Given this list of marker genes Tap1, Atp6v1d, Atp1a1, Abca12, Atp6v1a, Abcd4, Abcb11, Abca15, Abcb1a, Atp7a, Ipo8, Atp6v1g3, Kcnj8 (potassium inwardly-rectifying channel, subfamily J, member 8), Atp13a4, Abcb1b, Atp6v1e2 (ATPase, H+ transporting, lysosomal V1 subunit E2), Abcg2, Atp6v0e2, Atp1a3, Tap2, Atp6v0d2, Atp13a5, Atp6v1g1, Cftr, Abca16, Atp2b3, Cpox, Abcg8, Abca6, Abcg4, Atp2b2, Abcd3, Atp2b1, Abcc3, Atp2c2, Abca9, Atp6v1c2, Atp7b, Anxa5, Atp5f1b, Abcc6, Kcnj11, Atp6v0a2, Atp6v1e1, Atp5mg, Atp6v0e, Atp1b2, Atp2b4, Abcb4, Atp13a2, Atp6v0a1, Abca2, Atp4a, Atp2a1 (ATPase, Ca++ transporting, cardiac muscle, fast twitch 1), Abca17, Atp2c1, Abcg5, Abcc10, Abca3, Abca13, Atp6v1c1, Ralbp1, Atp5f1e, Abcc1, Abcg3, Atp6v0b (ATPase, H+ transporting, lysosomal V0 subunit B), Abcb8, Atp6v1b2, Atp6v1g2, Atp1b1, Abcc4, Abca4, Atp6v1f, Atp6v0a4, Atp12a, Abca8a, Atp1b3, Abcb6, Abcc9, Atp1a2, Abcc5, Atp6v1b1 (ATPase, H+ transporting, lysosomal V1 subunit B1), Atp6v0c, Abcb5, Abcd2, Atp6v0d1, Abca8b, Atp13a3, Bcs1l, Abcb10 (NCBI Gene Id 97438), Abcd1 (NCBI Gene Id 11666), Atp4b, Atp6v1h, Abca5, Tmem94, Atp2a2, Abcc8, Tomm20, Abcg1 (NCBI Gene Id 11307), Atp1a4, Abca1, Abcb9, Atp2a3, Abcc12, Atp13a1, Abcb7, Abca14, Abca7, Abcc2, here is a description of the gene set: Primary active transporter of a solute across a membrane, via the reaction: ATP + H2O = ADP + phosphate, to directly drive the transport of a substance across a membrane. The transport protein may be transiently phosphorylated (P-type transporters), or not (ABC-type transporters and other families of transporters). Primary active transport occurs up the solute's concentration gradient and is driven by a primary energy source. species: Mus musculus Mouse Gene Set: GOMF_ATPASE_COUPLED_TRANSMEMBRANE_TRANSPORTER_ACTIVITY